The following is a description of a gene set: studied in species Homo sapiens The process in which a relatively unspecialized cell acquires specialized features of a blood vessel endothelial cell, a thin flattened cell that lines the inside surfaces of blood vessels. Human Gene Set: GOBP_BLOOD_VESSEL_ENDOTHELIAL_CELL_DIFFERENTIATION, and this is the list of marker genes: DLL1, FOXJ2, HEY2, PROX1, HEY1, MIR34A, NRP1, LIPA, KDR, NOTCH1, TMEM100, RBPJ, MIR10A, CCM2